The following is a description of a gene set: species: Homo sapiens The epithelium-specific Ets transcription factor, PDEF, plays a role in prostate and breast cancer, although its precise function has not been established. In prostate cancer, PDEF is involved in regulating prostate-specific antigen expression via interaction with the androgen receptor and NKX3.1, and down-regulation of PDEF by antiproliferative agents has been associated with reduced PDEF expression. We now report that reduced expression of PDEF leads to a morphologic change, increased migration and invasiveness in prostate cancer cells, reminiscent of transforming growth factor beta (TGFbeta) function and epithelial-to-mesenchymal transition. Indeed, inhibition of PDEF expression triggers a transcriptional program of genes involved in the TGFbeta pathway, migration, invasion, adhesion, and epithelial dedifferentiation. Our results establish PDEF as a critical regulator of genes involved in cell motility, invasion, and adhesion of prostate cancer cells. from publication Gu X, Zerbini LF, Otu HH, Bhasin M, Yang Q, Joseph MG, Grall F, Onatunde T, Correa RG, Libermann TA (PMID 17483333) Human Gene Set: GU_PDEF_TARGETS_DN Integrin, VEGF, Wnt and TGFbeta signaling pathway genes down-regulated in PC-3 cells (prostate cancer) after knockdown of PDEF by RNAi., and this is the list of marker genes: CDH1, KRT19, SMURF1, KRT18, PIK3R4, KRT7, KRT6C, KRTAP9-9, INHBB, NKX2-5, HNF1A, KRT75, FOXC1, KRT3, CDH3, TGFB2, FZD5, KRT6A, FOXA1, CDH20, FOXO3, ITGB6, PI4KB, KRT33A, PIK3R3, FOXO1, EIF1AX, PARVA, EIF3C, PIK3CB, FZD10, EIF2B2, KRT34 (keratin 34), KRT8, ITGB8, THBS1, VEGFC, KRT6B, PIP4K2C, ITGB4